Given this list of marker genes Ptpn2, Pias1, Ifngr1, Ifngr2, Sumo1, Jak2, Socs1, Socs3, Ifng, here is a description of the gene set: Regulation of IFNG signaling Mouse Gene Set: REACTOME_REGULATION_OF_IFNG_SIGNALING species: Mus musculus